The following is a description of a gene set: species: Homo sapiens Genes predicted to be targets of miRBase v22 microRNA hsa-miR-3129-3p in miRDB v6.0 with MirTarget v4 prediction scores > 80 (high confidence targets). from publication Chen Y, Wang X (PMID 31504780) Human Gene Set: MIR3129_3P, and this is the list of marker genes: SRSF11, MAP1B, PDZRN3, ATF7IP, ASAP2, SCN8A, SPATA18, SELENOT, TEX12, ELOVL2, SETX, PPFIA2, GREB1, ANK2, S100PBP, CASR, ZEB1, TRMT10A, PTPRG, FAM169A, ATRX, TMEM106B, TLR8, GPC6, TENT4B, CDYL, CCL4L2, ETNK1, PTPRD, MARCHF5, IL20, KLHL24, MOXD1 (monooxygenase DBH like 1), PRRX1, CNTD1, ZC2HC1A, ADD3, EPHA3, TIPRL, PIK3C2A, PHLDA1, DMRTB1, ARF4, MLF1, SRSF1, RBBP8, BET1, CPSF6, GAD2, TRIM33, VEZF1, FRMD4A, LTN1, USP12, ZNF311, DLEU7, NR2C1, SLC25A24, WDPCP, CISD2, CCL4, CACNB4, EFR3A, GALNT3, NCAM2, CNOT6L, STAR, PTPN14, CADPS2, PTBP2, GRB14, CEACAM7, ZMYM2, NUTF2, PPP2CB, MDGA2 (NCBI Gene Id 161357), ARMCX1, B4GALNT1, LIN54, POLD3, ZBTB33, AFF4, TBC1D12, MCL1, TUBB2B, ADAM9, MBNL3, THAP6, TMTC3, CALU, SLC35A5, SEMA3E (NCBI Gene Id 9723), UVRAG, DDX3X, WAPL, PCM1, PDC, TMED2, UBE2E1, BOLA2-SMG1P6, RHOQ, TRMT9B, ARID2, SP8, CCDC152, UBE2D3, UBE3C